Given this list of marker genes Irf5, Slamf1, Map3k7, Il6, Trim6, Dhx36, Panx1, Dennd1b, Clnk, Prkcz, H2-T23, Gimap5, Ccl20, F2rl1, Sema7a, Nod1, Calhm6, Prg2, Ddx1, Laptm5, Ripk2, B2m, Mavs (NCBI Gene Id 228607), Angpt1, Cd36, H2-M3, Trpm4, Mif, Sash3, Ticam1, Tlr7, Tgfb3, Hmox1, Il10, Smad7 (NCBI Gene Id 17131), Wnt5a, Hk1, Il1b, Cuedc2, Clec7a, Rtn4, Fcer1a, Ccr2, Atg9a (NCBI Gene Id 98551), Tlr2, Mapkapk2, Malt1, Mir324, Vsir, Cd96, Pycard, Inava, P2rx7, Syk, Rsad2, Lilrb4b, Il18r1, Tnfsf4, Scimp, Card9, Cd55b (CD55 molecule, decay accelerating factor for complement B), Ifng, Ifnb1, Myd88, Rigi, Sirt1, Pkp3, Twist1, Gprc5b, Tlr4, Apoa1, Cd81, Lacc1 (laccase domain containing 1), Cd226, Nlrp3, Rabgef1, Tlr3, Plcg2, Apoa2, Sphk2, Tirap, Casp1, Arg1, Litaf, Ddx21, Traf2, Psg22, Tnfrsf14, Klrh1, Hfe, Il18, Ube2j1, Tek, Fcer1g, Casp4, Gimap3, Jak3, Nod2, Atg5, Cd160, Il1r1, Tbx21 (NCBI Gene Id 57765), Cd55, Tnf, Nr4a3, Arid5a, Twist2, Il4, Foxp3, Lilrb4a, Axl (NCBI Gene Id 26362), Epx, Tlr9, Ffar3 (NCBI Gene Id 233080), Kit, Tgfb1, Nlrx1, Bcl6, Traf6, Gata3, Htr2a, Fzd5, Bst2, Il21, Tril, Irak3, Spon2, Tgfb2, Acp5, Cd74, Ffar2, Xcl1, Tnfrsf1b, here is a description of the gene set: Mouse Gene Set: GOBP_REGULATION_OF_CYTOKINE_PRODUCTION_INVOLVED_IN_IMMUNE_RESPONSE Any process that modulates the frequency, rate, or extent of cytokine production that contributes to an immune response. species: Mus musculus